The following is a description of a gene set: Human Gene Set: HP_CLINODACTYLY_OF_THE_4TH_TOE Bending or curvature of a fourth toe in the tibial direction (i.e., towards the big toe). Clinodactyly of the 4th toe studied in species Homo sapiens, and this is the list of marker genes: NOG, FRA10AC1, COG8, RAB3GAP2, HEPHL1